Given this list of marker genes RPS4X, RPL21, SYT10, RPL14, RPS19, MYL3, TCF7L2, RPL29, FTHL17, RPL4, RPS7, RAVER2, PTMS, RPS8, RPL10, EEF1B2, KIF21B, RPS5, EIF3H, NSA2, RPS6, DNM1, RPS3, CYP17A1, ARID5B, EIF3F, CPT1B, LALBA, RACK1, EEF1G, RPL18A, EEF1A1, KHSRP, RPL6, here is a description of the gene set: from publication Bilanges B, Argonza-Barrett R, Kolesnichenko M, Skinner C, Nair M, Chen M, Stokoe D (PMID 17562867) The tuberous sclerosis complex (TSC) proteins TSC1 and TSC2 regulate protein translation by inhibiting the serine/threonine kinase mTORC1 (for mammalian target of rapamycin complex 1). However, how TSC1 and TSC2 control overall protein synthesis and the translation of specific mRNAs in response to different mitogenic and nutritional stimuli is largely unknown. We show here that serum withdrawal inhibits mTORC1 signaling, causes disassembly of translation initiation complexes, and causes mRNA redistribution from polysomes to subpolysomes in wild-type mouse embryo fibroblasts (MEFs). In contrast, these responses are defective in Tsc1(-/-) or Tsc2(-/-) MEFs. Microarray analysis of polysome- and subpolysome-associated mRNAs uncovered specific mRNAs that are translationally regulated by serum, 90% of which are TSC1 and TSC2 dependent. Surprisingly, the mTORC1 inhibitor, rapamycin, abolished mTORC1 activity but only affected approximately 40% of the serum-regulated mRNAs. Serum-dependent signaling through mTORC1 and polysome redistribution of global and individual mRNAs were restored upon re-expression of TSC1 and TSC2. Serum-responsive mRNAs that are sensitive to inhibition by rapamycin are highly enriched for terminal oligopyrimidine and for very short 5' and 3' untranslated regions. These data demonstrate that the TSC1/TSC2 complex regulates protein translation through mainly mTORC1-dependent mechanisms and implicates a discrete profile of deregulated mRNA translation in tuberous sclerosis pathology. Genes translationally repressed upon serum deprivation in MEF cells (embryonic fibroblast). species: Mus musculus Human Gene Set: BILANGES_SERUM_RESPONSE_TRANSLATION